The following is a description of a gene set: Any process that decreases the frequency, rate or extent of a digestive system process, a physical, chemical, or biochemical process carried out by living organisms to break down ingested nutrients into components that may be easily absorbed and directed into metabolism. species: Mus musculus Mouse Gene Set: GOBP_NEGATIVE_REGULATION_OF_DIGESTIVE_SYSTEM_PROCESS, and this is the list of marker genes: Wnk3, Isx, Hamp2, Tifab, Wnk1 (WNK lysine deficient protein kinase 1), Nr1h3, Npsr1, Hamp, Abcg2, Abcg8, Stk39, Gpr39, Nmu, Sct, Neurog1, Wnk4, Ptger3, Tff2, Crhr2, Abcg5 (NCBI Gene Id 27409)